The following is a description of a gene set: Mouse Gene Set: MIR_450A_1_3P_MIR_450B_3P species: Mus musculus from publication Chen Y, Wang X (PMID 31504780) Genes predicted to be targets of miRBase v22 microRNA mmu_miR_450a_1_3p, mmu_miR_450b_3p in miRDB v6.0 with MirTarget v4 prediction scores > 80 (high confidence targets)., and this is the list of marker genes: Olfml1, Nipal1, Cybrd1, Abcf3, Prkn, Hdgfl3, Gpc6, Atp6v1g3, Sim1, Gulp1, Lactb, Sfrp1 (NCBI Gene Id 72362), Lzts3, Ostn, Reep5, 1110059G10Rik, Slc30a7, Prx, Chd9, Uevld, Hspa13, Gpr101, Pak5, Rfx3, Armcx4, Mansc1, Zmynd11, Cadm1, Dpysl3, Heca, Esp1, Pcdhb15, Cngb3, Tmed4, Ints12, Zfp9, Sgcz, Rbbp7, Mbnl3, Msr1, Ablim1, Tmed7, Sostdc1, Phf20 (NCBI Gene Id 228829), Irf1, Mtf2, Paqr4, Ptprk, Pcdhb9, 5730507C01Rik, Stk3, Shisal2b, Sars1 (seryl-tRNA synthetase 1), Cbx2 (chromobox 2), Slc1a3, Cbll1, Cd247, Dbpht2, Psat1, Bcas1, Hdx, Gls (glutaminase), Nsd1, Zeb1, Gprasp2, Thumpd2, Rab14, Crispld1, Sprr2f, Aak1, Pias3, Sgpp1, Sf3b3, Slc25a21, Trim39, Atg4c, Arhgap44, Best1, 2510009E07Rik, Zfp874b, Eny2, Evi2a, Plekhh1, Tenm4 (teneurin transmembrane protein 4), Mobp, Prdm2, Clip3, Ddx6, Rad1, Nhsl1, Cyp4a14, Tafa1, Tesk2, Scp2, Lhx9, Wdr72, Gpbp1l1, Mkrn1, Phf8l, Bnc1, Krtap4-16, Trps1, Sephs2, Gne, Jade3, Tox, Clvs1, Bmp2, Lce3a, Six5, Bmp3, Krtap2-20, Cldn34d, Gopc, Prdm8, Wbp1l, Megf10, Utp4, Srsf5, Crisp4, Saxo1, Pou2f1, Fhl3, Psip1, Pappa, Mef2c, Frmpd4, Relch